The following is a description of a gene set: Human Gene Set: GSE2770_IL4_ACT_VS_ACT_CD4_TCELL_2H_UP Th1 and Th2 cells arise from a common precursor cell in response to triggering through the TCR and cytokine receptors for IL-12 or IL-4. This leads to activation of complex signaling pathways, which are not known in detail. Disturbances in the balance between type 1 and type 2 responses can lead to certain immune-mediated diseases. Thus, it is important to understand how Th1 and Th2 cells are generated. To clarify the mechanisms as to how IL-12 and IL-4 induce Th1 and Th2 differentiation and how TGF-beta can inhibit this process, we have used oligonucleotide arrays to examine the early polarization of Th1 and Th2 cells in the presence and absence of TGF-beta after 0, 2, 6 and 48 hours of polarization. studied in species Homo sapiens Genes up-regulated in CD4 T cells activated by anti-CD3 and anti-CD28: IL4 (2h) versus untreated (2h). from publication Lund R, Aittokallio T, Nevalainen O, Lahesmaa R (PMID 14607935), and this is the list of marker genes: PTDSS2, CSNK2B, AP3B1, DIS3L, RFC1, MRPL34, ELOF1, TOB1, SASH3, NDUFB3, GUK1, HES6, SAR1B, SPATA13, ACLY, UBE2E3, BACH2, TIMM21, SLC46A1, ADH5, NIT2, COPS7B, AP2S1, ABHD5, MFSD1, AK3, MPHOSPH6, MACROD1, ACAA1, NME7, SUMF1, STAM, TUBG1, STRN, PEF1, ZFYVE19, AMACR, RFWD3, CAMK2G (NCBI Gene Id 818), PRXL2B, HELLS, SLIRP, MPND, TRIOBP, ZNF365, PPIB, UHRF1, FKBP4, RALB, DNAJC15, RPS11, MTHFD2L, SLF1, GM2A, PAPSS1, SCP2 (sterol carrier protein 2), APEH, SEC11C, RWDD4, F2R, IFI27L2, TRAPPC2 (trafficking protein particle complex subunit 2), IGSF8, ZNF229, STRADA, MFF, ARFIP1, MANBA, LASP1, CCDC124, PRDX2, NDUFB8, C4orf46, MPV17L2, LAMTOR2, MAVS, ARHGAP21, NANP, WDR53, NDUFB9, MRPL14 (mitochondrial ribosomal protein L14), SREK1IP1, DDIT4, HOPX, TPGS2, QNG1 (NCBI Gene Id 84267), PRKCB, MRPL27, ZFP64, MED9, VPS28, NAA10, CDC7, TMCO3, CIAO3, CDC34, SUGP1, DNAJC3, PPP1CA, PRKD2, CYRIB, PDLIM1, VOPP1, MTFP1, SLC25A14, RPP30, COX8A, COX6B1, MRPL11, VPS36, CARS2, RP2, MAPRE2, MPPE1, INCENP, DEF6, FAAP20, ZNF493, RBL2, GALNT7, ORMDL2, FCSK, JPT1, MPC2, PGPEP1, ZNF623, CORO1B, NCF4, GMPPB, PARK7, ING1, NFATC2, HDDC2, ACO1, LMAN2, NUDT1, SLBP, GTPBP3, UBQLN2, PXN, WDR13, RNF146, SBK1, TSFM, RGS10, PTPN9, POGLUT2, TMEM160, EEIG2, PYCARD, EXTL3 (NCBI Gene Id 2137), UGDH (UDP-glucose 6-dehydrogenase), EIF2B1, LBR, PTRH1, RXYLT1, ARHGDIB, SLAIN1, SIN3B, ABCB7, BST2, MRPL28, FBXW2, NAE1, MRPL30, TEX261, TMA7, NDUFS5, GNB2, SCRN2, SH3BP1, C2orf69, PRPS2, EBP, PGP, GPI, UBE2T, MRPS33, TRAPPC2L, NCAPH2, MAPK14, NSF, PPP1R21 (protein phosphatase 1 regulatory subunit 21), MKNK2, ABRACL, CTSA, DHX9, NAA20 (N-alpha-acetyltransferase 20, NatB catalytic subunit), ENO1, PAGR1, CDS2, FAM210B, UQCC3, MAP3K4, NDUFA4, GUF1, TUBB2B (NCBI Gene Id 347733), EIF5A2, BLOC1S1, MLF2